Given this list of marker genes Sh3rf2, Sfrp4, Gstp3, Dusp3, Klhl31, Aida, Gstp1, Nppa, Gstp2, Prmt1, Cdc42se1, F2rl1, Dusp19, Akt1, Dusp10, Sfrp5, Prkn (NCBI Gene Id 50873), Gps2, Per1, Pafah1b1, Hdac3, Cyld (NCBI Gene Id 74256), Dnaja1, Ptpn22, Mapk8ip1, Marveld3, Hipk3, Itch, Fktn (fukutin), Dact1, Men1, Mecom, Gstp-ps, Sirpa, Zmynd11 (zinc finger, MYND domain containing 11), Sfrp2, Ncor1, Sfrp1, Pdcd4, Taok3, here is a description of the gene set: Any process that stops, prevents, or reduces the frequency, rate or extent of signal transduction mediated by the JNK cascade. Mouse Gene Set: GOBP_NEGATIVE_REGULATION_OF_JNK_CASCADE studied in species Mus musculus